Given this list of marker genes AURKA, TAOK2, RBBP8, RAD21, DONSON, NBN, CLSPN, HUS1B, CDC25A, CDK6, CCND1, STK35, RAD51B, PABIR1, CCNB1, DTL, PDIK1L, PLK1, CCNQ, BRCC3, USP17L2, MIR195, ZFYVE19, BABAM2, SMARCD3, ATM, PKIA (NCBI Gene Id 5569), FZR1, MTA3, BRD4, NABP2, CTC1, BRSK1, RNASEH2B, TP53, NEK10, RAD51C, MACROH2A1, HEXIM2, NAE1, MARK3, TAOK1, GPR132, PHOX2B (paired like homeobox 2B), MRNIP, ING4, RFPL1, CDK3, HSPA2, CDK1, FOXN3, TRIM39, CHFR, ZNF830, PBX1, BLM, DBF4B, ATAD5, CDC25C, CDC25B, MBTPS1, CENPF, RAD17, INTS3, VPS4A, SYF2, PKMYT1, MIIP, BRCA1, CDK10, CHMP4C, GTPBP4, ATF5, PINX1, IER3, SIN3A, RRM2B, ORC1, CDC6, DYRK3, CDKN1A, NABP1 (nucleic acid binding protein 1), AVEN, NOP53, CDK5RAP3, ETAA1, ABRAXAS1, RAD50, RAB11A (NCBI Gene Id 8766), FBXO5, PAXIP1, KCNH5, HUS1, BARD1, CDK2, INIP, TOPBP1, UIMC1, CDK4, AURKB, CDC14B, MRE11, RRM1, CDC7, USP50, STOX1, WNT10B, MBTPS2, TICRR, KIF14, FOXO4, MIR19B1, FHL1, NPM1, RINT1, TAOK3, CHEK1, RCC2 (regulator of chromosome condensation 2), VPS4B, ATR, WEE1, BABAM1, here is a description of the gene set: species: Homo sapiens Human Gene Set: GOBP_REGULATION_OF_CELL_CYCLE_G2_M_PHASE_TRANSITION Any signaling pathway that modulates the activity of a cell cycle cyclin-dependent protein kinase to modulate the switch from G2 phase to M phase of the cell cycle.